The following is a description of a gene set: Human Gene Set: GOBP_NEGATIVE_REGULATION_OF_STEROID_HORMONE_SECRETION Any process that stops, prevents or reduces the frequency, rate or extent of steroid hormone secretion. studied in species Homo sapiens, and this is the list of marker genes: PTPN11, CRY2 (cryptochrome circadian regulator 2), CRY1, TSPO, KCNK9